The following is a description of a gene set: Human Gene Set: GAO_SMALL_INTESTINE_24W_C9_ENTEROENDOCRINE_CELL from publication Gao S, Yan L, Wang R, Li J, Yong J, Zhou X, Wei Y, Wu X, Wang X, Fan X, Yan J, Zhi X, Gao Y, Guo H, Jin X, Wang W, Mao Y, Wang F, Wen L, Fu W, Ge H, Qiao J, Tang F (PMID 29802404) studied in species Homo sapiens, and this is the list of marker genes: GFRA2, LINC02208, PCDH8, SLC36A4, LOX, ACSM1, PCDH10-DT, FBXL7, MEI4, TRPC3, RASA1, NANOS1, TRIQK, ASB8, C1QTNF3, RHBDD1, RFX3-DT, P4HA2-AS1, AOX1, DPT, BEND4, SH3GL1P1, ENSG00000275765, MADCAM1, ITIH4-AS1, LSAMP-AS1, METTL1, APCDD1, SACS (NCBI Gene Id 26278), SCP2D1-AS1, PPP1R18, RPL23AP82 (NCBI Gene Id 284942), ACBD4, ZBBX, ELANE, CPZ, LINC01354, ARMH4, ZNF608 (zinc finger protein 608), LINC00942, ISLR, TOE1, MSC, RTL5, KCNAB1-AS1, WHAMMP3, ZNF503-AS1, PRDM14, HOXC11, TRIM62, PLSCR5, SHISA3, FAM162B, CHMP1B2P, MIR646HG, POMGNT2, LINC00299, CPA1 (NCBI Gene Id 1357), TTLL3, ARSI, AKR1D1, NTF3